The following is a description of a gene set: Human Gene Set: GOBP_PROLINE_BIOSYNTHETIC_PROCESS studied in species Homo sapiens The chemical reactions and pathways resulting in the formation of proline (pyrrolidine-2-carboxylic acid), a chiral, cyclic, nonessential alpha-amino acid found in peptide linkage in proteins., and this is the list of marker genes: OAT, NOXRED1, PYCR2, ALDH18A1, PYCR1, PYCR3